Given this list of marker genes Oprm1, Arpp19, Foxo1, Sirt7, Tcf7l2, Prkag3, Ppp4r3b, Sirt1, Gpt, Hif1a, Ptpn2 (protein tyrosine phosphatase, non-receptor type 2), Kat2a, Ppara, Ddb1, Prkag1, Hnf4a, Prkaca, Gcg, Stk11, Dgat2, Ppp4r3a, Supt20, Prkag2, Wdr5, Cyp2j6, Kat2b, Nnmt, Cry1, Pfkfb1, here is a description of the gene set: Any process that activates or increases the frequency, rate or extent of gluconeogenesis. Mouse Gene Set: GOBP_POSITIVE_REGULATION_OF_GLUCONEOGENESIS studied in species Mus musculus